Given this list of marker genes Lipa, Larp1, Nanog, Hnf1a, Ifitm5, Arpc2, Golph3, Hnrnpd, Foxp3, here is a description of the gene set: Any process that results in a change in state or activity of a cell or an organism (in terms of movement, secretion, enzyme production, gene expression, etc.) as a result of a rapamycin stimulus. studied in species Mus musculus Mouse Gene Set: GOBP_RESPONSE_TO_RAPAMYCIN